The following is a description of a gene set: Human Gene Set: GOMF_DYNEIN_COMPLEX_BINDING species: Homo sapiens Binding to a dynein complex, a protein complex that contains two or three dynein heavy chains and several light chains, and has microtubule motor activity., and this is the list of marker genes: NUMA1, ATMIN, CFAP73, HDAC6, TPR, CFAP100, FBXW11, GPSM2, KASH5 (KASH domain containing 5), PPP1R42, DCTN6, PAFAH1B1, CENPF, FMR1, DNAAF1, BICD2, NEFH, RAB29, BICD1, SNCA, KATNB1, SMC3, APC, DNAAF8